The following is a description of a gene set: species: Homo sapiens Marker genes curated from the annotated cluster as represented in the Descartes Human Gene Expression During Development database. from publication Cao J, O'Day DR, Pliner HA, Kingsley PD, Deng M, Daza RM, Zager MA, Aldinger KA, Blecher-Gonen R, Zhang F, Spielmann M, Palis J, Doherty D, Steemers FJ, Glass IA, Trapnell C, Shendure J (PMID 33184181) Human Gene Set: DESCARTES_FETAL_HEART_STROMAL_CELLS The gene expression program underlying the specification of human cell types is of fundamental interest. The study authors generated human cell atlases of gene expression and chromatin accessibility in fetal tissues. For gene expression, the study authors applied three-level combinatorial indexing to >110 samples representing 15 organs, ultimately profiling ~4 million single cells. The study authors leveraged the literature and other atlases to identify and annotate hundreds of cell types and subtypes, both within and across tissues. Our analyses focused on organ-specific specializations of broadly distributed cell types (such as blood, endothelial, and epithelial), sites of fetal erythropoiesis (which notably included the adrenal gland), and integration with mouse developmental atlases (such as conserved specification of blood cells). These data represent a rich resource for the exploration of in vivo human gene expression in diverse tissues and cell types., and this is the list of marker genes: DCN, TCF21, ISLR, LUM, LPAR4, ANGPTL1, RTL3, NPTX2, PCOLCE, ABCA9 (NCBI Gene Id 10350), GPC3, EMILIN3 (elastin microfibril interfacer 3), FBLN1, PTN, CCN3, ADAMTS2, COL1A2, C1QTNF12, CILP, PRELP, ABCA10, TARID, PDGFRA, NRK, SERPINF1, MFAP5, AGTR2, ANGPTL6, DPT, ADAMTS19, CCL11, SCARA5, COL1A1, HTRA3